Given this list of marker genes GBP2 (guanylate binding protein 2), ARMC5, ONECUT2 (NCBI Gene Id 9480), TREML1, ELL, ATP6V1G2, SP100, TRAF3, PPT1, AICDA, GNG2, SSMEM1, CMYA5, PGBD5, DDX20, DNAJB13, RABGEF1, ANXA7, CSMD3, CSRNP3, OGFRL1, SRI, PPP4R1, FGF14 (fibroblast growth factor 14), WNT9B, PIGX, MBNL1, VSIG1, ING3, SUGP2, RPS6KA5, MYRIP, SNTG1 (NCBI Gene Id 54212), SEC24B, SHPRH, GPM6B, PTPN20, ZFPM2, TYR, ELMO2, OSBPL8 (NCBI Gene Id 57601), PHF2, TRPM8, CP, ZNF432, KLHL11, ARHGAP5, TMEM243, ARHGAP31, NAA50, NPNT (NCBI Gene Id 255743), MAN2A1 (NCBI Gene Id 4124), HECW1, ITGA4, TMEM263, LRRTM1, SLITRK2, PIK3CB, UNC45B, CCDC88A, TTLL3, MEP1A, RPF2, IPCEF1, TAOK1, MAT2A, TBCA, UBAP1, LMAN1, SELENOV, DNAJC9, AKAP11, CA3, WTIP, PAK1IP1, HDAC4, KBTBD3, ZNF711 (NCBI Gene Id 7552), FAM8A1, FAM43B, CLDND1, OPCML, PSMD1, BSN, USP9Y, here is a description of the gene set: from publication Chen Y, Wang X (PMID 31504780) Genes predicted to be targets of miRBase v22 microRNA hsa-miR-7161-3p in miRDB v6.0 with MirTarget v4 prediction scores > 80 (high confidence targets). studied in species Homo sapiens Human Gene Set: MIR7161_3P